The following is a description of a gene set: studied in species Mus musculus The chemical reactions and pathways resulting in the formation of phosphatidylinositol phosphate. Mouse Gene Set: GOBP_PHOSPHATIDYLINOSITOL_PHOSPHATE_BIOSYNTHETIC_PROCESS, and this is the list of marker genes: Pik3r1, Pik3ca (NCBI Gene Id 70742), Pi4kb, Itpkb, Pi4k2a, Pik3cg, Ttc7b, Pip5k1b, Smg1, Pip4k2a, Uvrag, Pik3r4, Pip5k1a, Atm, Pik3cb, Pip5k1c, Efr3b, Pik3c2g, Pik3cd, Inpp4a, Pip4k2c, Ptprq, Impa2, Impa1, Ip6k1, Hycc2, Pi4ka, Tmem150a, Bpnt1, Pik3c2b, Pi4k2b, Atg14, Pik3c3, Ip6k2, Inpp5e, Pip4k2b, Fig4, Pip5kl1, Inpp1, Hycc1, Ip6k3, Inpp4b, Pik3c2a, Bpnt2, Itpkc, Itpka (inositol 1,4,5-trisphosphate 3-kinase A), Becn1 (beclin 1, autophagy related), Ttc7